Given this list of marker genes Ifi202b, Igfbp3, Cth, Iigp1, Plp1, Jpt1, Phgdh, Pam, Nnat, Nfkb2, Pira1, Coq8a, Bcl6 (NCBI Gene Id 12053), Idh1, Reep6, Ice1, Cap1, Nfia, Fabp3-ps1, Rpl36a, Trac, Zbtb16, Wfdc21, Cox7a1, Anxa8, Cdkn1a, Mbp, Rpl14, Txndc16, Rps10, Mmd2, Timp4, Ifi204, Trbc2 (NCBI Gene Id 100125263), Rgs2, Ighm, Prkag2, Ripor2, Nrip1, Hp, Lck (NCBI Gene Id 16818), Ndufv2, Alas1, Tcf7, here is a description of the gene set: studied in species Mus musculus Genes down-regulated during pubertal mammary gland development between weeks 3 and 4. Mouse Gene Set: MCBRYAN_PUBERTAL_BREAST_3_4WK_DN Expression microarray analysis identified over genes regulated during puberty in the mouse mammary gland. Most prominent were genes whose expression increased in parallel with pubertal development and remained high thereafter. Members of the Wnt, transforming growth factor-beta and oestrogen-signalling pathways were significantly overrepresented. Comparison to expression data from CITED1 knockout mice identified a subset of oestrogen-responsive genes displaying altered expression in the absence of CITED1. Included in this subset are stanniocalcin2 (Stc2) and amphiregulin (Areg). Chromatin immunoprecipitation revealed that ERalpha binds to oestrogen response elements in both the Stc2 and Areg genes in the mammary gland during puberty. Additionally, CITED1 and ERalpha localize to the same epithelial cells of the pubertal mammary gland, supporting a role for interaction of these two proteins during normal development. In a human breast cancer data set, expression of Stc2, Areg and CITED1 parallel that of ERalpha. Similar to ERalpha, CITED1 expression correlates with good outcome in breast cancer, implying that potential maintenance of the ERalpha-CITED1 co-regulated signalling pathway in breast tumours can indicate good prognosis. from publication McBryan J, Howlin J, Kenny PA, Shioda T, Martin F (PMID 17486082)